Given this list of marker genes Ldb2, Dab2 (NCBI Gene Id 70555), Pappa, Sparcl1, Fbln1, Aldh1a1, Aspn, here is a description of the gene set: from publication Schaeffer EM, Marchionni L, Huang Z, Simons B, Blackman A, Yu W, Parmigiani G, Berman DM (PMID 18794802) Mouse Gene Set: SCHAEFFER_PROSTATE_DEVELOPMENT_AND_CANCER_BOX6_UP Early prostate development genes (up-regulated at 48 hr dihydrotestosterone) which are also up-regulated in high grade prostatic intraepithelial neoplasia (PIN) vs invasive cancer. Cancer cells differentiate along specific lineages that largely determine their clinical and biologic behavior. Distinct cancer phenotypes from different cells and organs likely result from unique gene expression repertoires established in the embryo and maintained after malignant transformation. We used comprehensive gene expression analysis to examine this concept in the prostate, an organ with a tractable developmental program and a high propensity for cancer. We focused on gene expression in the murine prostate rudiment at three time points during the first 48 h of exposure to androgen, which initiates proliferation and invasion of prostate epithelial buds into surrounding urogenital sinus mesenchyme. Here, we show that androgen exposure regulates genes previously implicated in prostate carcinogenesis comprising pathways for the phosphatase and tensin homolog (PTEN), fibroblast growth factor (FGF)/mitogen-activated protein kinase (MAPK), and Wnt signaling along with cellular programs regulating such 'hallmarks' of cancer as angiogenesis, apoptosis, migration and proliferation. We found statistically significant evidence for novel androgen-induced gene regulation events that establish and/or maintain prostate cell fate. These include modulation of gene expression through microRNAs, expression of specific transcription factors, and regulation of their predicted targets. By querying public gene expression databases from other tissues, we found that rather than generally characterizing androgen exposure or epithelial budding, the early prostate development program more closely resembles the program for human prostate cancer. Most importantly, early androgen-regulated genes and functional themes associated with prostate development were highly enriched in contrasts between increasingly lethal forms of prostate cancer, confirming a 'reactivation' of embryonic pathways for proliferation and invasion in prostate cancer progression. Among the genes with the most significant links to the development and cancer, we highlight coordinate induction of the transcription factor Sox9 and suppression of the proapoptotic phospholipid-binding protein Annexin A1 that link early prostate development to early prostate carcinogenesis. These results credential early prostate development as a reliable and valid model system for the investigation of genes and pathways that drive prostate cancer. studied in species Mus musculus